Given this list of marker genes ELOB, FBXL15, PRAMEF6, KEAP1, TRIM45, PRAMEF7, TOPORS, SENP1, CDC16, PEX12, PLAA, KLHL22, NAGLU, SIRT2, NEDD4L (NCBI Gene Id 93998), PSMD11, PSMA4, DAB2, FBXO44, TRIM38 (NCBI Gene Id 10475), CUL3, PSMB1, CDC20B, MAP1A, PCBP2, GIPC1, BTRC, NPLOC4, UBE2N, UBE2D3, MARCHF6, RFPL1, TRIM13, AKT1, CDC27 (cell division cycle 27), PHF20L1 (PHD finger protein 20 like 1), PSMB8, ASB2, KCTD5, DERL1, SIAH3, AGAP3, NHLRC1, AFG2B, CRBN, CSNK2A2, LRRK2, USP38, RNF187 (NCBI Gene Id 149603), NSFL1C, PLK1, TRIM9, FBXL19, KLHL42, PCNP, NFE2L2, UBE2C, PSMA7, SUMO1, USP44, PIAS1, TBL1X, ASCC2, TRIM26 (tripartite motif containing 26), BMAL1, FBXO2, UBR3, DTL, N4BP1, UBR5, ANAPC13, ARRB2, PSMB6 (NCBI Gene Id 95505), CAMLG, APC2, STUB1, SH3RF1, FBXW8, TBX21, AXIN2, KLHDC10, KLHL41, SHARPIN, CUL4A, USP9X, KBTBD8, UBR7, GCLC, SOCS2, PRAMEF13, FBXO9, CDC20, FBXO46, SIRT6, CSNK2A1, KLHDC2, FBXO22, FBXO31, KLHL30, SYVN1, PRAME, HSP90AB1, RNF186, CEBPA, ZNRF1, SEM1 (NCBI Gene Id 7979), UBE2W, PSMD13, FBXL14, ATXN3, SMAD7, ARIH2, IFI27, SIAH2, TRIB1 (tribbles pseudokinase 1), PSMD14, ECRG4, BAG5 (BAG cochaperone 5), FEM1B, ZFAND2B, LRRC75A, KLHL21, RAD23A, BAG6, TRIP12, KLHL23, WWTR1, KLHL29, KLHL12, FBXW4 (F-box and WD repeat domain containing 4), HUWE1, PSMD3, CSNK1A1, PPP2R5C, RNF139, DDRGK1, UBQLN4, WWP2, RNF126, KLHL4, TLK2, PRAMEF1, WNT10B, ZNF418, PRAMEF25, SMURF2, PABPN1L, KLHL40, FBXO11, DMAC2, OGT, DDIT3, SOCS4, HFE, CDC34, RMND5B, ANAPC11, PRAMEF2, ARRB1, KCTD13, AXIN1, FBXL22, SMURF1, PRAMEF17, PSMD6, FBXL3, UBE2A, DCAF12, UBE2K, SHH, RNF180, TRIM28, KLHL10, SPSB2, FBXO48, KLHL7, COMMD1, TRIM71, PRAMEF10, DET1, ARMC5, RNF34, UBE4B, ZYG11B, PABIR1, PML, PSMA3, PRAMEF33, PSMA5, ANAPC7, KLHL8, KLHL28 (kelch like family member 28, NCBI Gene Id 54813), BBS7, UBXN1 (NCBI Gene Id 92151), FBXO38, PRICKLE1, CLOCK, STYX, KLHDC3, ZSWIM8, UBR4, PAQR3, SPOP, PRAMEF14, HECTD3, SH3BGRL, PSMB2, KLHL3, RNF145, UCHL1, UFL1, GID8, FBXO17, UBXN2A, FAF2, IL33, TRPC4AP, UBE3A, KIF14, SIAH1, FBXW7, TRIP4, RNF10, KLHL38, ARMC8, PRAMEF26, FBXW11, SKP1, USP14, VCP, TAF1, RAD23B, WDR26, CUL2, PSMC3, VHL, SIRT1, AURKA, RBCK1, ANKRD9, CSNK1E, PRAMEF15, FBXL18, KCMF1, FBXL16 (F-box and leucine rich repeat protein 16), FOXF2, PSMD10, PSMC2, FBXO6, CDC26, RMND5A, KLHL15, NEMF, CSNK1D, UBR2, ERCC8, CBFA2T3, APC, KAT5, GSK3B (glycogen synthase kinase 3 beta), KLHL5 (NCBI Gene Id 54163), DDA1, KBTBD2, PRAMEF5, PBK, NHLRC3, GABARAP, FBXL5, PSMC6, SPSB1, FBXO45, KBTBD3, PSMD4, FBXO4, SH3RF3, XPO1, UBR1 (NCBI Gene Id 64703), PSMB7 (NCBI Gene Id 5695), HAMP, ADRM1, SH3RF2, RACK1, SMARCC1, TRIM72, PSMD12, ANAPC15, UBE2G1, HERC2 (NCBI Gene Id 8924), NUB1, PSMD2, UBXN11, SPSB4, TRIM39 (NCBI Gene Id 56658), TAF9, CLU, FBXO7, ZFAND2A, PSMB11, PRAMEF22, PRAMEF9, PLK3, PJA2, ASB9, FBXL4, RHOBTB3, HSPA1A, MAPK9, BIRC2, UBE2U, HSPA1B, ASB1, DNAJB2, CDC23, SPOPL, ANAPC1, TF, UBE3D, DTX4, ANAPC4, APPBP2, PRAMEF4 (NCBI Gene Id 400735), RPL11, RYBP, PSMC5, PSMA2, ANAPC2, RNF7, UBE2H, GNA12, AKIRIN2, MTA1, PRAMEF19, NKD2, UCHL5, KLHL17, FBXL20, KLHL35, KLHL24, SOCS5, RCHY1, TRIB3, PRAMEF12, FBXL6, UBXN7, KLHL18, HSPBP1, FBXW5, MAEA, UBXN2B, IPP, KLHDC1, PSMC4, PSMB3, PRAMEF20, RBX1, PRAMEF11, GBA1, ZER1, HECTD1, UBE2S, PSMD1, KLHL6, COP1, DESI1, PANO1, TNFAIP1, TRAF4, PRAMEF18, ATXN3L, BAG2, TRIB2, FAF1, PRAMEF27, KLHL2 (kelch like family member 2), UBE2B, PSMA1, WWP1, CTNNB1, DDB1, PSMF1, PELI1, PSEN1, PSMA6, PRKN, KBTBD12, PEX10, MDM2, NOP53, CUL5, LTN1, CCNF, EPM2A, SUMO2, TRIM2, CHFR, FBXL2, ANAPC16, TTC36, KBTBD6, KLHL11 (NCBI Gene Id 55175), PSMB10, UFD1, CCAR2, RNF4, ANAPC10, ITCH, KLHL1, IVNS1ABP, GAN, FBXL7, CDK2, KCTD17, GSK3A, FBXO3, PSMB4, PARK7, SOCS7, PRAMEF8, ZNF598, RNF170, ARAF, NCCRP1, CSNK2B, FZR1, FEM1A, AMBRA1, UBE2D1, ARHGAP5-AS1, RNF122, ASCC3, PSMB9, ASB11, TRIM3, DVL1, CCIN, KBTBD7, AMN1, ANAPC5, USP26, RFFL, TBL1XR1, DCAF13, SPSB3 (splA/ryanodine receptor domain and SOCS box containing 3), PSMA8, USP5, FHIT, WAC, PSMD8, FBXO27, RNF216 (ring finger protein 216), PPP2CB, PSMD7, FEM1C, PSMC1, GLMN, FBXL13, PSMB5, KCTD2, CUL1, ZNRF4, FBXO39, DCAF1 (NCBI Gene Id 9730), MTM1, USP7, DCAF11, BFAR, KLHL20, ZNRF2, FBXL17, SKP2, EIF3H, KCTD10, GID4, here is a description of the gene set: Human Gene Set: GOBP_PROTEASOME_MEDIATED_UBIQUITIN_DEPENDENT_PROTEIN_CATABOLIC_PROCESS studied in species Homo sapiens The chemical reactions and pathways resulting in the breakdown of a protein or peptide by hydrolysis of its peptide bonds, initiated by the covalent attachment of ubiquitin, and mediated by the proteasome.